The following is a description of a gene set: Any process in which the nucleus is transported to, and/or maintained in, a specific location within the cell. species: Mus musculus Mouse Gene Set: GOBP_NUCLEUS_LOCALIZATION, and this is the list of marker genes: Dock7, Fbxw11, Bin1, Pafah1b1, Sirt1, Myh10, Tacc1, Hook3, Dmd, Pcm1, Slit1, Sun2, Cep120, Cav3, Syne3, Kif1a, Cdc42, Ptk2, Clmn, Lmna, Bltp1, Dync1h1, Pax6, Nherf1, Sun1, Nudc, Tacc3, Hhex, Dctn1, Tacc2, Lmnb1, Tmem201, Cdc42bpa, Lmnb2, Syne1, Tlk2, Fhod1, Syne2, Pabpc1l, Ehbp1l1, Ntn1, Trim58, Mtor, Cdk9